The following is a description of a gene set: Human Gene Set: REACTOME_MIRO_GTPASE_CYCLE Miro GTPase Cycle species: Homo sapiens, and this is the list of marker genes: MYO19, MFN1, MFN2, RAP1GDS1, TRAK1, RHOT1, RHOT2, TRAK2